Given this list of marker genes Bcl2, Snai2, Itgb1, Itga5, Ptrh2, Ntrk2, Src, Bcl2l1, Pik3ca, Tle1 (transducin-like enhancer of split 1), Ptk2, Cav1, Mcl1, Notch1, Pdk4, here is a description of the gene set: studied in species Mus musculus Any process that stops, prevents or reduces the frequency, rate or extent of anoikis. Mouse Gene Set: GOBP_NEGATIVE_REGULATION_OF_ANOIKIS